The following is a description of a gene set: The chemical reactions and pathways resulting in the formation of glycosphingolipid, a compound with residues of sphingoid and at least one monosaccharide. studied in species Mus musculus Mouse Gene Set: GOBP_GLYCOSPHINGOLIPID_BIOSYNTHETIC_PROCESS, and this is the list of marker genes: Fut9, St6galnac3, B3galt4, Fa2h, Ugt8a, Tm9sf2, B4galt6, St8sia2, St8sia3, St6galnac5, St3gal1, St3gal2, St8sia4, B3galt2, Gal3st1, St8sia6, B4galt4, St8sia5, St3gal3, St6galnac1, B3galt1, B4galnt1, St6galnac4, A4galt, Fut4, B4galt5, St6galnac6, B4galt3, Ugcg, A3galt2, 6430550D23Rik